Given this list of marker genes TGFBR1 (transforming growth factor beta receptor 1), ACVR1C, ACVR2B, ACVR1B, ACVR1, TGFBR2, BMPR2, ACVR2A, ACVRL1, here is a description of the gene set: Human Gene Set: GOMF_ACTIVIN_RECEPTOR_ACTIVITY studied in species Homo sapiens Combining with activin and transmitting the signal from one side of the membrane to the other to initiate a change in cell activity. Activin is one of two gonadal glycoproteins related to transforming growth factor beta.